Given this list of marker genes ATL1, HK1, MFN2, CCT5, RNF170, HINT1, SPTLC1, DHH, SPTLC2, NAGA, DMD, here is a description of the gene set: Distal sensory impairment of all modalities Human Gene Set: HP_DISTAL_SENSORY_IMPAIRMENT_OF_ALL_MODALITIES species: Homo sapiens Reduced ability to sense pain, temperature, touch, vibration stimuli in the distal regions of the extremities.